Given this list of marker genes DYNLT3, LIG1, UROD, CIPC, TAF9, SLC66A1, GK, DTYMK, TMEM216, TMEM223, CYBC1, EXT1, PALD1, PPFIA4, TSPAN31, GNB5, CYRIB, TP73, SLC25A10, DDT, NDUFS2, UBR7, HAUS5, ZBTB14, RPS6KA1, HSPH1, CBR3, DPH5, SRXN1, BBS9, DAP, MCM7, SEC24D, KCTD1, ECI1, NCBP1, DEF8, ACAA2, NOA1, SLC44A2, ECHDC1, POLR1C, TULP3, PLD1, HSD3B7, YPEL1, MTRES1, POLA2, SLIRP, VDAC3, FAM210B, ABCD4 (NCBI Gene Id 5826), SPIRE2, GANAB, PRPF6, NHERF2, DPY30, RCHY1, LAS1L, TUFM, RPP14, SNAP47, CD2BP2, NME6, SETD6, SRM, OSBPL2, MRPS22, NIT2, PNPLA7, PAICS, CLU, VDAC1, PSEN2, MCFD2, MED29, NRDE2, PC, PRKCSH, RBM28, SSX2IP, SDF2, MYDGF, EIF5, TLR1, ATP5F1D (ATP synthase F1 subunit delta), SMPDL3A, KCTD12, SLC25A11, TLR4, NPY4R, CTSH, NDUFV2, IGFBP4, DERL2, SELENBP1, NBR1, PRAF2, ITM2B, KCNAB2, SPIDR, TMEM126A, HIGD1C, GSTZ1, RIOK2, TMEM205 (transmembrane protein 205), ALKBH3, BPNT1, TMED7, SLC25A4, MRPS33 (mitochondrial ribosomal protein S33), PTEN (phosphatase and tensin homolog), AKR7A2, COPG2 (COPI coat complex subunit gamma 2), ITPR3, CRADD, TBCC, GADD45A, ORC5 (origin recognition complex subunit 5), DRG1, GPR180, ST6GAL1, ABHD4, SLC46A3, TXNL4A, RPL19, GINS4, DRG2, IL10, ARCN1, PRKRA, ZNF707, PAFAH2, PNKD, TRMT10B, GAB3, NDUFA8, WWOX, RNF128, NRDC, MAPK14 (mitogen-activated protein kinase 14), CWC27, DBNDD2, PARP16, SNTG1, PTPN14, PRICKLE1, NUP210, DCN, RABGGTA, TM2D3, STK26, CD1D, FARSB, PLA2G7, SSBP4, MRPL41 (mitochondrial ribosomal protein L41), RB1, TMT1A, HSPA4L, GPR65, CSE1L, DCTPP1 (dCTP pyrophosphatase 1), BCL2L14, FBXW2, CSDE1, MPND, PIGS, TMEM14C, THAP11, KMT5C, STOM, MESD, STMN1, H2AZ1 (H2A.Z variant histone 1), TEF, CLPP, UTP4, DNAJB4, DUSP19, CSN2, SERF2, EIF1AX, EMC7, SMYD5, GATC, LRRC18, AOAH, UBE2B, UQCRHL, PCMTD2, FOS, SELENOH, CSRP3, PXMP4, NDUFA11, FCGR3A (Fc gamma receptor IIIa), TTLL1, MRPL37, SH3BGRL2, here is a description of the gene set: from publication Amit I, Garber M, Chevrier N, Leite AP, Donner Y, Eisenhaure T, Guttman M, Grenier JK, Li W, Zuk O, Schubert LA, Birditt B, Shay T, Goren A, Zhang X, Smith Z, Deering R, McDonald RC, Cabili M, Bernstein BE, Rinn JL, Meissner A, Root DE, Hacohen N, Regev A (PMID 19729616) Human Gene Set: GSE17721_12H_VS_24H_GARDIQUIMOD_BMDC_DN species: Homo sapiens Genes down-regulated in comparison of dendritic cells (DC) stimulated with Gardiquimod (TLR7 agonist) at 12 h versus those stimulated with Gardiquimod (TLR7 agonist) at 24 h. mouse primary BMDCs were stimulated with tlr ligands and gene expression changes were profiled on Affymetrix arrays